Given this list of marker genes FGF12, CHP1, SCN1B, TESC, STK39, GRP, ACTN4, WNK2, WNK3, OSR1, FGF13, here is a description of the gene set: Human Gene Set: GOBP_REGULATION_OF_SODIUM_ION_TRANSMEMBRANE_TRANSPORTER_ACTIVITY studied in species Homo sapiens Any process that modulates the frequency, rate or extent of sodium ion transmembrane transporter activity.